The following is a description of a gene set: Sialyl lewis x antigen biosynthesis. Pathway ID: N01674. Pathway type: Reference. Pathway class: nt06035 Blood group carbohydrate antigen biosynthesis. Pathway Definition from KEGG: nLc4Cer -- ST3GAL6 -> snLc4Cer -- FUT3/4/5/6/7 -> SLex species: Homo sapiens Human Gene Set: KEGG_MEDICUS_REFERENCE_SIALYL_LEWIS_X_ANTIGEN_BIOSYNTHESIS, and this is the list of marker genes: FUT7, FUT3, FUT5, FUT4, ST3GAL6, FUT6